The following is a description of a gene set: A protein complex that contains G protein-coupled receptors. species: Homo sapiens Human Gene Set: GOCC_G_PROTEIN_COUPLED_RECEPTOR_COMPLEX, and this is the list of marker genes: RAMP2, RAMP1, GPR156, GRM1, DRD1, DRD2, RAMP3, CALCRL, GABBR1, GABBR2, CALCR (calcitonin receptor)